The following is a description of a gene set: species: Homo sapiens Neighborhood of PPM1D Neighborhood of PPM1D protein phosphatase 1D magnesium-dependent, delta isoform in the GCM expression compendium Human Gene Set: GCM_PPM1D, and this is the list of marker genes: ZFTA, ZNF566, RBM4B, EXOC5, LMNB1, KMT5B, ESRRG, CEP170, PARP6, CELF1, ANKRD50, PPM1D, WBP11, KAT6B, KAT7, ZHX1, VEZF1, PPM1E, SPAST, NUDT4 (NCBI Gene Id 57236), SMC3, PTBP2, TOMM70, SYNC, NAA25, USP37